The following is a description of a gene set: Human Gene Set: GOBP_GLUTAMINE_FAMILY_AMINO_ACID_BIOSYNTHETIC_PROCESS species: Homo sapiens The chemical reactions and pathways resulting in the formation of amino acids of the glutamine family, comprising arginine, glutamate, glutamine and proline., and this is the list of marker genes: GOT1, ASS1, GLUD2, PYCR2, GLS2, ALDH18A1, NAGS, GLS, OTC, OAT, NOXRED1, LGSN, CLN3, PYCR1, GLUD1, ASL, GLUL, PYCR3